The following is a description of a gene set: part of: Nucleotide salvage Reactome Pathway: Purine salvage species: Homo sapiens Nucleosides and free bases generated by DNA and RNA breakdown are converted back to nucleotide monophosphates, allowing them to re-enter the pathway of purine biosynthesis and interconversion. Under normal conditions, DNA turnover is limited and deoxyribonucleotide salvage operates at a correspondingly low level., and this is the list of marker genes: AMPD2, PNP (NCBI Gene Id 4860), ADA, ADK, HPRT1, APRT, AMPD1, DCK, GMPR2 (guanosine monophosphate reductase 2), MAPDA, GMPR, DGUOK (NCBI Gene Id 1716), AMPD3